The following is a description of a gene set: Mouse Gene Set: CUI_CDC2_IL18_RESPONSE_UP Cytokines mediate cell-cell communication in the immune system and represent important therapeutic targets. A myriad of studies have highlighted their central role in immune function, yet we lack a global view of the cellular responses of each immune cell type to each cytokine. To address this gap, the authors created the Immune Dictionary, a compendium of single-cell transcriptomic profiles of more than 17 immune cell types in response to each of 86 cytokines (>1,400 cytokine-cell type combinations) in mouse lymph nodes in vivo. A cytokine-centric view of the dictionary revealed that most cytokines induce highly cell-type-specific responses. For example, the inflammatory cytokine interleukin-1β induces distinct gene programmes in almost every cell type. A cell-type-centric view of the dictionary identified more than 66 cytokine-driven cellular polarization states across immune cell types, including previously uncharacterized states such as an interleukin-18-induced polyfunctional natural killer cell state. species: Mus musculus Genes positively differentially expressed in cell type: cDC2 (conventional dendritic cell type 2) upon treatment with cytokine: IL-18 in mouse lymph nodes in vivo. from publication Cui A, Huang T, Li S, Ma A, Pérez JL, Sander C, Keskin DB, Wu CJ, Fraenkel E, Hacohen N (PMID 38057668), and this is the list of marker genes: Hadhb, Tmed9, Snx2, Stx11, Pnp, Srpra, Gabarap, H2-DMb1, Ostc (oligosaccharyltransferase complex subunit (non-catalytic)), Nup98, Tnfrsf1a, Pfkp, Nfkb2, Nras, Prpf31, Denr, Txndc9, Srsf7, Arl1, Zbp1, Myo1e, Atp11b, Srm, Pdcd10, Rrbp1 (NCBI Gene Id 81910), Psmb8, Psma4, Klrk1, Wdr43, Idnk, Ssr3 (signal sequence receptor, gamma), Tes (testin LIM domain protein), Kars1, Apobec3, Pdcd6ip, Serp1, Cfb, Cish, Pgs1, Igtp, Mat2a, Actr2, Rab3il1, Ywhag, Stx7, Fcgrt, Ms4a4c, Ms4a6b, Pim1, Hbegf, Irgm1, Mitd1, Irgm2, Batf3, Sumo2, Casp1, Efhd2, Gpbp1, Calr, Aida, Diaph1, Tor1aip2, Slc15a3, Tap2, Samhd1, Chmp4b, Cd274, Oasl2, Rap2c, Cisd2, Capg, Ranbp1, Rnf213, Sdc4, Cxcl9, Gadd45g, Ifi213, Ifi211, P2ry14, Spint1, Ifit1, Uso1, Psma2, Ccl2, Cd164, Snap23, Gda, Tapbpl, Phf11b, Tmod3, Dynll1, Malt1, AA467197, Nod1, B4galt3, Cltc, Marchf5 (NCBI Gene Id 78729), Rab8b (NCBI Gene Id 235442), Nckap1l (NCK associated protein 1 like), Gbp5, Hnrnph2, Mbd2, Stat3, Ndufb7, Gprc5c, Aqp3 (NCBI Gene Id 230080), Ralgds, Lrrc59, Txn1, Gtf3c6, Dnajc2, Slc33a1, Cox8a, Ffar2, C3, Socs1, Pa2g4, Uqcrfs1, Icam1, Snrpd1, Irf5, Edem1, Hnrnpdl, Cttnbp2nl, Vasp, Derl2, Slc30a4, Txnrd1, Gbp8, Arl6ip5, Csf2rb, Jpt1, Cdkn1a, Zup1, Atp6v1e1, Gnb4, Dnajc3, Nherf1, Casp8, Atp5pb, Pml, Cdk2ap2, Nr4a3, Il10ra, Ifi204, Mkrn1, Ube2l6, Psma3, Rnf115, Litaf, Eno1, Pkib, Ywhae, Kynu, Hspa5, Dcun1d1, Trappc6b, Gbp2, Serpina3g, Stt3a, Clic4, Psma5, Ifi35, Gsap, Irf1, Ly6a, Zyx, Jaml, Rtp4 (NCBI Gene Id 67775), Calm1, Spred1 (sprouty protein with EVH-1 domain 1, related sequence), Ubxn4, Notch1, Tor3a, Tapbp, Lcp1, Zfp800 (zinc finger protein 800), Cd40, Mpeg1, Trim12c, Ass1, Sbno2, Srsf2, Ogfr, Tpst1, Tspo, Ifi27l2a, Ifih1, Eif5a, Sdad1, Rara, Cd209e, Mgl2, Slco3a1, Psmb5, Uck2 (uridine-cytidine kinase 2), Hspa8, Sarnp, Tpm3, Herc6 (NCBI Gene Id 74620), Nop58, Il1rn, Gbp4, Hif1a, Kdr, Rbbp8, Ppa1, Tmed5, Rbm8a (RNA binding motif protein 8a), Clec10a, Atp1a1, Tle3, Naaa, Pdcd1lg2, Dbnl, Fcgr4 (NCBI Gene Id 320130), Pfdn2, Slfn8, Sod2, Picalm, Prkcd, Cmpk1, Glrx, Usp18, Dram1, Sec23b, Tpm4, Ccdc59, Ccdc25, Cct7, Man2a1, Ifit2, Cd53, Parp14, Nfkb1, Sting1, Cst3, Creld2, Cdh1, Clec2d, Hdlbp, Nlrc5, Lrrk1, Pfdn1, Tma16, Necap2, Selenos, Ms4a6d, Lpl, Aamp, Qpct, Lyn, Gosr2, Tap1, Magohb, Ripk1, Rwdd1, Abhd16a, Dnajc21, Sertad2, Dnajb11, Psmd7, Nmi, Parp9, Kdm5c, Psmb4, Runx1, Ctsz, Naa25, Sh3bgrl, Vcam1, Isg15, Rap2a, Sec61a1, Larp1, Slfn2, Gmppb (GDP-mannose pyrophosphorylase B), Ly6e (lymphocyte antigen 6 family member E), Slfn1, Psmc5, Ciao2b, Kmo, Xbp1, Slamf8, Chd7, Rab5c, Vrk1, St7, Psmb6, Rbx1, Arhgap31, Stat1, Irf4, Vdr, Rab7, Mrpl54, Pkm, Vdac2 (NCBI Gene Id 22334), Ube2a, Cox6b1, Foxn3, Lgals3bp, Dck, Parp12, Prps1, Eif1, Arpc2, Atp6v0a1, H2-Q7, Tmbim6, Hprt1, Gpr35, Cyrib, Anxa4, Cnn3, Fcgr2b, Parl, Ece1, P2ry13, Parp10, Ube2s, Bst1, Usp25, Arf1, Cmtm6, Noc4l, Etf1, Gfra2, Susd6, Ccdc115, Rab1a, Cldnd1, Slfn5, Eif4g1, Tagap, Hnrnpd, Pfn1, Gbp9, Cct8, Dok2, Pdia6, Arid5a, Capn1, Atp5f1b, Cyp4f16, Psmb10, Gna13, Nrp2, Macroh2a1, Dennd1a, H2-T23, Fgl2, Arf3, Creb3, Ccl12, Ifi206, Ly86, Mrpl17, Plek, Rbms1, Tnf, Eml4, Ehd1, Atp5mc1, Fkbp1a, Timm17a, Ifi205, Sp110, Spi1, Ly6i, Gatm, Cox7a2, H2-D1, Hivep1, Eif4a1, H2-K1, Bcl3, Slc31a1, Mdh2, Orai1, Pgk1, Il4ra, Plac8, Psme2, Enah, Rnf19b, Cyba, Rigi, Prkx, Camk2d, Trim30a, Serpina3f, Psmb9, Arl4a, Eif2ak2 (NCBI Gene Id 76759), Procr, Pin1, Il21r, Calhm6, Irf7, Socs2, Upp1, Tor1aip1, Tuba1b, Flt1, Il15ra, Mrc1, Ddx39a, Slc2a1, Fam241a, Etnk1, Hcar2, Eef1e1, Tnfaip2, Ciita, Snu13, Pcbp1, Psme1, Lcp2, Dtx3l, Arap2, Mob3c, Mvp, Csf2rb2, Med21 (NCBI Gene Id 97336), Cemip2, Daxx, Ifi207, Fh1, Nrros, Pkdcc, Plet1 (placenta expressed transcript 1), Sppl2a, B2m, Tmem131, Sav1, Eif6, Atp6v1a, Eif1a, Ilrun, Ube2n, Capza2 (NCBI Gene Id 76913), Creb5, Sell, Arl8b, Gbp3, Irf8, Cflar, Fnbp1l, Max, Cycs, Psmc4, Eif4g2, Zdhhc5, Cggbp1, Slc3a2, Lrrc8c, Mndal, Coro2a, Batf2, Ube2i, Riok3, Tmem167, Pmvk, Slc4a7, Mapkapk2, Il2rg, Srp19, Fcer1g, Psma7 (proteasome subunit alpha 7), Stat2, Pdia4, Actr3, Arf4, Gadd45b, Cox17, Bcl2a1d, Ranbp2, Cers6, Hs3st3b1, Sdcbp, Sirpb1c, Hipk2, Pdia3, Tmem131l, Clec4n, Rmdn3, Gpr146, Myd88, Cstb, Fcgr3, Bach1, Hsp90b1, Cd44, Bcl2a1b, Nlrp3, Sf3b6, Xaf1, Phf11d, Scimp, Cebpb, Plaur, Gpr171, Dnajb9, Snx3, Ebp, Hnrnpab, Mt1, Pomp, Hhex, Fyn, Gbp7, Tarm1, Oas3, Atp2a2, Myl12a, Atp2c1, Oas1a, Rars1, Aif1, Spcs2, Mrpl3, Arid4a, Wdr1, Ssr2, Tmem106a, Cox7b, H2-Q4, Hk3, Lap3, Znfx1, Iigp1, Cd300lf, Ngfr, Trio, Syncrip, Pcgf5, Luc7l3, Psmd14, Wars1, Eps8, Casp4 (NCBI Gene Id 12363), Fabp5 (fatty acid binding protein 5, epidermal), Polr2k, Tuba4a, Tspan13, Ggct (gamma-glutamyl cyclotransferase), Ube2d3, Fas, Eif2s1, Il27, Nt5c3, Napsa, Rbm3, Prkd3, Ldlr, Bbip1, Nampt, Socs3, Eif3a, Aco2, Manf, Jak2, Cxcl10, Ifi209, Ninj1, Stard3, Vim, Ifi47, Clec12a, Ran, Gca, Trafd1, Zfand3, Ccl17, Rhoh, Ifi203, Mrpl20, Ccdc86, Ak2, Ssb, Lamp2, Sp140, Rap1a (NCBI Gene Id 99734), S100a6, BC031181, Bcl2a1a, Skap2, Ugcg, Flot2, Srsf3, Ptpn1, Mtdh, Vps37b, Actg1, Srgn, Ccr5, Sar1a, Trim30d, Rab21, H13, Pfdn6, Plaat3, Pik3cd, Pacsin2, Cacybp